The following is a description of a gene set: Any process that modulates the frequency, rate or extent of synaptic vesicle transport. Human Gene Set: GOBP_REGULATION_OF_SYNAPTIC_VESICLE_TRANSPORT species: Homo sapiens, and this is the list of marker genes: LRRK2, BORCS5, PINK1, PRKN, MAP2